The following is a description of a gene set: species: Mus musculus Any process that activates or increases the rate or extent of mammary gland epithelial cell proliferation. Mouse Gene Set: GOBP_POSITIVE_REGULATION_OF_MAMMARY_GLAND_EPITHELIAL_CELL_PROLIFERATION, and this is the list of marker genes: Rreb1, Kdm5b, Mst1, Iqgap3 (IQ motif containing GTPase activating protein 3), Ccnd1, Zfp703, Rtn4, Agap2